The following is a description of a gene set: studied in species Homo sapiens A major goal of systems biology is the development of models that accurately predict responses to perturbation. Constructing such models requires the collection of dense measurements of system states, yet transformation of data into predictive constructs remains a challenge. To begin to model human immunity, we analyzed immune parameters in depth both at baseline and in response to influenza vaccination. Peripheral blood mononuclear cell transcriptomes, serum titers, cell subpopulation frequencies, and B cell responses were assessed in 63 individuals before and after vaccination and were used to develop a systematic framework to dissect inter- and intra-individual variation and build predictive models of postvaccination antibody responses. Strikingly, independent of age and pre-existing antibody titers, accurate models could be constructed using pre-perturbation cell populations alone, which were validated using independent baseline time points. Most of the parameters contributing to prediction delineated temporally stable baseline differences across individuals, raising the prospect of immune monitoring before intervention. from publication Tsang JS, Schwartzberg PL, Kotliarov Y, Biancotto A, Xie Z, Germain RN, Wang E, Olnes MJ, Narayanan M, Golding H, Moir S, Dickler HB, Perl S, Cheung F, Baylor HIPC Center, CHI Consortium (PMID 24725414) Genes positively correlated with cell frequency CD27hi CD38hi of CD20- B cells (Plasmablasts) and CD38+ of IgD-CD27+ memory B cells in peripheral blood mononuclear cell in adults after exposure to Fluvirin/Pandemrix, time point 7D Human Gene Set: TSANG_PBMC_FLUVIRIN_PANDEMRIX_ADULT_CORR_WITH_CELL_FREQ_CD27HI_CD38HI_CD20_NEG_PLASMABLASTS_AND_CD38PLUS_OF_IGD_CD27PLUS_MEM_B_CELLS_7DY_POSITIVE, and this is the list of marker genes: HSPA13, MYO1D, CCNB2, BUB1, IGHV4OR15-8 (NCBI Gene Id 388078), ERLEC1, CCNA2, JCHAIN, DTL, UAP1, TSHR, KIF11, PCLAF, PLAAT2, IGKC, PLPP5, B4GALT3, FBH1, SUB1, ZBP1, H2BC14, SHCBP1, MAN1A1, IRF4, PIM2, H1-5, KLHL14, TOP2A, GLCCI1, KCNN3, SLC44A1, FBXO16, TP53INP1, BHLHE41, PBK, MEI1, PARM1, DENND5B, MTDH, ARHGAP42 (NCBI Gene Id 83935), H3C12, CHEK1, UBE2J1, MKI67, PLK1, MAGED1, RRM2 (NCBI Gene Id 6241), CDK1, SEC11C, DIPK1A, GPRC5D, CD38, TNFRSF17, SPATS2, IGKV4-1, FBXO5, ELL2, XBP1 (X-box binding protein 1), DLGAP5, HSPA5, MANEA, LMAN1 (NCBI Gene Id 3998), RGS13, CHAC2, PDIA4, TRAM2, APOBEC3B, NT5DC2, TYMS, TPD52, CAV1, SEL1L3, HSP90B1, PHGDH, SEC24A, ITM2C, RAB30, SPCS3